The following is a description of a gene set: p75(NTR)-mediated signaling studied in species Homo sapiens from publication Schaefer CF, Anthony K, Krupa S, Buchoff J, Day M, Hannay T, Buetow KH (PMID 18832364) Human Gene Set: PID_P75_NTR_PATHWAY, and this is the list of marker genes: PLG, FURIN, ZNF274 (zinc finger protein 274), RAC1, APH1B, PIK3CA, RHOB, NCSTN, BDNF, PRKCI, BIRC3, CASP3, MAPK8 (NCBI Gene Id 5599), BIRC2, PIK3R1, SHC1, CASP9, E2F1, IKBKG, MAGED1, PRKACB, SMPD2, BEX1, PRKCZ (protein kinase C zeta), NGFR, NDN, BEX3, SQSTM1, DIABLO, MAGEH1 (MAGE family member H1), OMG, APH1A, NSMCE3, IKBKB, NGF, APP, MYD88, BAD (BCL2 associated agonist of cell death), ARHGDIA, RHOA, CYCS, AKT1, APAF1, RTN4, MMP7, CHUK, SORT1, RTN4R, NTRK1, ADAM17, YWHAE, TRAF6, NTF3, CASP6, RHOC, MAPK9, PSENEN, BCL2L11, PSEN1, NTF4, RIPK2, MAPK10, XIAP, MAG, TP53, IRAK1, MMP3, PRDM4